The following is a description of a gene set: A biological process that directly contributes to the process of producing new individuals by one or two organisms. The new individuals inherit some proportion of their genetic material from the parent or parents. studied in species Homo sapiens Human Gene Set: GOBP_REPRODUCTIVE_PROCESS, and this is the list of marker genes: LRGUK, STAU1, HSPG2, GHRL, MTA2, TDRD5, ADAMTS16, ITGB3, AVPR1A, FZR1, RFX2, C1QBP (complement C1q binding protein), GDF7, TTC12, ADAM29, CDYL, CTCFL, CCNA1, MAPK15, DIRAS3, FOLR2, KDM3A, SYCE1, SPIN2A, TACR2, TMED2, DEFB126, ZP2, ADAM28, E2F8, CATSPERZ, ATP1A4, TH, BSPH1, PGAM2, SFRP1, PRKG1, MARF1, GLIPR1L2, LHFPL2, PAFAH1B3, IHH, LSM14B, NUF2, MEIKIN, NR6A1, NCAPH, PIWIL4, CDK16, HOXD13, TAC1, CLDN11, MOS, GABRB3, KDM2B, SPIN4, SLC19A1, VIPAS39, CYLC1, AKT1, PGK2, OSBP2, SKA1, PTPRN, DDB1, SLC2A14, INSR, CABYR, FOXA1, TSPY1, CDC20, KRT19, GLRA1, NELL2, CCNB1, ROBO2, OSR1, SPOCD1, SYCP2, STK33, EDN1 (endothelin 1), AKAP3, AAAS, MTOR, PKD1, CITED2, SLC6A4, OOEP, HERPUD2, AURKA, MGAT4D, IRAG2, SUN5, TCTE1 (t-complex-associated-testis-expressed 1), PSG2, AREG, AKR1C3, ERCC4, TESK2, SMC2, WT1, HMGA2, ELL3, PIERCE1, SGO2, AGO4, FAM9C, CDY2B, ENDOU, BCL2L1, KAT8, SPATA31A1, SPIN3, PRKACA, KIFC1 (NCBI Gene Id 95229), SULF1, B4GALT1, SKA2, DNHD1, DLG1, DHCR24, CATSPERG, PPP1R9B (NCBI Gene Id 84687), HMGB2, DND1, HEXB, DAZ1, RAD51C, PHB2 (NCBI Gene Id 11331), NPM2 (nucleophosmin/nucleoplasmin 2), ACVR2A, NCAPD3, JAM3 (NCBI Gene Id 84887), GHRHR, OSGIN2, NDN, BNC1, SPMAP2, FAM9B, IFT20, SUN2, GLRB, PTGDR2, SMC1A, SAFB2, RNF8, HOXB13, RBX1, DNAH1, WNT3, PLN, CALCA, CFAP61, HUS1B, SETX (NCBI Gene Id 85506), DNAH5, CNOT9, TMEM232, TPPP3, TRIP13, ABAT, BMP4, SERPINE2, BCL2L2, CCDC40, UTP14C (UTP14C small subunit processome component), NKAPL, TSSK4, TUBGCP5, PTTG3P, FGFR2, FOXF2, FOLR1, GARIN1A, STK35, SEPTIN12, ZAR1L (zygote arrest 1 like), TLE6, BMPR2, SLC26A3, NBN, NLRP5, FAM170A, TMEM203, DMRTA1, IQCF1 (NCBI Gene Id 132141), PAFAH1B1, EIF5A2, WDR48, EQTN, TSSK6, SOX3, RAD54B, ZNF830, CIMIP2A, FOXJ3, TUT4, ITGA5, RPS6KA2, ODF1, RBMY1B, RHBDD1, SPAG8, TAF7L, NPFF, BRCA2, PAQR5, P2RY1, BAK1, CBX2, PMFBP1, RNF151, FANCL, FAM170B, CNBD2, AKAP4, MAPK8IP2, PTHLH, MSX1, STK3, CFAP68, FCRL3, CAPN2, HNF1B (HNF1 homeobox B), MEI4 (NCBI Gene Id 101928601), PARP1, SLX4, KPNA6, GLIPR1, SEMG2, SSX1, TUBA8, LYZL6, TRIM36, DNAAF3, PSG3, THRA, ARMC12, ITGA2, BCAP31 (NCBI Gene Id 10134), GCM1 (glial cells missing transcription factor 1), DNAI1, CCDC159, CDY1, PGAM4, SMC3, HNF4A, NANOS3, HAND1, TOP6BL, EFHC1, OR2H2, CREM, FER, WIPF3, STRBP, TBC1D21, GPR3, INSRR, CASP8, TTK, TSSK2, VMP1, TXNRD3, KIF18A, NPR2, PIWIL2, TFAP2C, SCX, EIF2B2, EOMES, KIF9, ACOX1, SLC26A8, TLR3, ADAM32, SPAG16, CFAP107, CRTAP, GDF10, CCNI, PSG7, CCDC136, GARIN2, CENPS, C2CD6, PZP, NPPC, ADCYAP1R1, ST14, PFN4, ESPL1, CFAP161, CCIN, GATA1 (GATA binding protein 1), LDHC, H1-9P, ZC3H14, TOPAZ1, LAMB1, COL6A1 (collagen type VI alpha 1 chain), SPINT2, WNT7A (NCBI Gene Id 7476), SPINK13, ADAM30, MLH3, NOS3, EHMT2, FUT10, SPINK1, CDC27, CORIN, SPANXB1, INPP5B, SRD5A1, RPL29, FGF10, PRKAG1, LDOC1, H3-3B, FOXC1, CGA, SNU13, PITHD1, FSHR, PIWIL1, SPATA2, ALPL, METTL3, CACNA1H, PRMT7, FZD4, SCGB1A1, CRIP1, SPATA31A6, PROK2, FEM1B, CFAP206, MASTL, TOP2B, MORC1, YTHDC2, WEE2, GDF9, TYRO3, GNPDA1, CFAP47, INTS1 (integrator complex subunit 1), YIF1B, NR2F2, SPAG17, YTHDF3, CRKL, STAT5B, CHD7, IGF2R, TAF4, TEKT5, TEKT1, CRISP3, PTCH1, OR1D2 (NCBI Gene Id 4991), MEI1, IGFBP7, SPTBN4, ADGRG2, SSTR1, ATRX, CRH, RIMS1, CBY3 (NCBI Gene Id 647934), B4GALNT1, MEIOB, NME8, MYH9, TUT7, UBB, NODAL (nodal growth differentiation factor), CFAP58, BMP7, ACSBG2, UBE2Q1, DDO, TEAD4, ORC4, BMP6, H3-4, PLA2G3, VPS13B, SPMIP7, TSGA10, SPATA31A3, ASB1, CTNNA1, CCR6, EPOR, SLC2A8, SPMIP8, THRB, RHOBTB3, REDIC1 (NCBI Gene Id 283461), TUBGCP2, SPAM1, BPY2, SPACA6 (NCBI Gene Id 730718), RBM7, PSG11, SEBOX, HERC2, INCENP, PRM2, RETN, GSK3A, PATZ1, SNAI1, FUT7, KATNAL1, SEPTIN6, LARP7, DEDD, HOOK1, RNF212B, H2BC1, PDILT, BASP1, SMAD3, SPATA31D3, HROB, CEP57, KRT8, PANX1, PKMYT1, RPA1, PARK7, QKI, SPDYA, NOTCH1, ADGB, CRISP1, NKX3-1, DPCD, SLCO4C1, PRSS21, TEX14, MAGED2, SPHK2, EME2, AFG2A, CCDC39, ADIG, TP63, C9orf78 (chromosome 9 open reading frame 78), ADAM18, EMP2, GJA1, PPARD, ITPR1, CCDC63, TRPC6, SOX15, AVP, CATSPER2, USP9Y, CCT7, TIFAB, ADAM21, NPAS1, IL1A, PKDREJ, SLC4A2, IZUMO3, CELF3, ENSG00000274276, PRKDC (protein kinase, DNA-activated, catalytic subunit), TTLL5, CEP131, SPATA19, DMRT1, DPY19L2, CCDC146, SKIL, RAD21, ANG, PTPN11, RAB3A, MUS81, FBXW11, VGF, TPPP2, TIMP1 (NCBI Gene Id 7076), TDRD6, TEX15, SFRP2, LEP, SPIN2B, SMAD2, CFAP141, DRD1, CT55, PSG6, PRR19, NECTIN2, SPAG6, CTCF, SNRPA1, DHX37, AGO2 (argonaute RISC catalytic component 2), FANCG, CSF1, SPACDR, SELENOF, DRC1, TTLL9, OR7C1, CFAP90, CCNO, ESR1, DUSP21, BTG1, SOHLH1, DSG2, HERC4, DCST1, GATA4, HVCN1, NEURL1, CADM1, ANAPC13, MST1R, SEPTIN7 (NCBI Gene Id 989), WASHC5, DLD, DAZAP1 (DAZ associated protein 1), PTGFR, SYT6, FSHB, SOX9, VEGFA, GORASP2, HDAC2, SPMIP10, IZUMO1, SMAD5, DMC1, SRPK1 (NCBI Gene Id 6732), MYCN, PSG4 (NCBI Gene Id 91051), UBE3A, PLG, ASH1L, BOK, CHN2, AGFG1, NTRK1, SAXO4, NUMA1, DNAJB6, STOX2, SOX30, SOHLH2, POC1A, TSNAXIP1, PNLDC1, AMHR2, CDC16, ODAD3 (outer dynein arm docking complex subunit 3), TARBP2, SMC1B, BCL6, CLXN, PSMC3IP, PDE3A, SLC2A1, ZDBF2 (NCBI Gene Id 57683), MKKS, COL16A1, PLA2G4C, GHSR, GAS2, AGFG2, IQUB, SPEM3, SEPTIN4, WBP2NL, MSTN, ARHGDIB, CATSPER1, MROH2B, SLC9C1, DDX3Y, FBXO43, LLCFC1, DCAF17, HOXA13, CDC23, TNFAIP6, HSD17B3 (hydroxysteroid 17-beta dehydrogenase 3), FAM9A, UNC5C, SYT8, ADRA2A, TNP2, SPAG11B, ACTR3, CETN2, CLOCK, ACE, PTGIS, UBAP2L, NANOS1, P3H4, PLCB1, TRO, KIAA0319L, WNT5A, HEXA, ANGPT2, IQCH, RPL39L, RXRB, EPN1, ENKUR, RXFP1, CCDC42, SPATA31A5 (SPATA31 subfamily A member 5), PTX3, CCER1, RIMBP3B, ROPN1, COX7B2, IL11RA, SIRT7, ZMYND12, TBPL1, STS, CATSPERE (catsper channel auxiliary subunit epsilon), CFAP77, PAPPA, SPATA6, TGFB1, CFTR, UBR2, GFRA1, TEX12, CFAP57, KMT2D, EPC1, DNAAF6 (NCBI Gene Id 139212), LEPR, CYLC2, AMH, DHX36, SEPTIN1, GGNBP1, LHCGR, RBBP8, ING2, SYCE1L, USP26 (ubiquitin specific peptidase 26), CYP19A1, MCM9, BPY2C, ROPN1L, KASH5, BRDT, EAF2, FAM50A, MAK, TRIM27, EFHC2, SELENOP, ABCB1, C16orf92, HPGDS (hematopoietic prostaglandin D synthase), PRDX4, SLC9B1, CCND1, PPP2R1A, TERB2, GALNT3, TTLL3, SMURF2, DRC7, OR10J1, CDC25B, VDAC2, ZFPM2, SOX17, CFAP276, EME1, BBS1, FOXJ1, LRRC46, ELSPBP1, HAS2, CLIC4, TERF1 (NCBI Gene Id 7013), XKRY, REC8, TCP11, CSDE1, PTN, SPIRE2, NOTCH4, GAMT, SALL1, SOX8, PSG5, CFAP97D1, ACTL9, KNL1, LGR4, HCN1, TUBG2, RACGAP1, DCST2 (DC-STAMP domain containing 2), CFAP20, ZGLP1, ZNF541, KDM1B, TSSK1B, DUSP13B, DNALI1, KITLG, FANCM, CATSPER3, CNTFR, CGB7, H1-1, TRIM75, SPACA9, ADAMTS1, SP3, NR0B1, AFF4, PRND, AGRP, IQCN, KHDRBS1, FETUB, CFAP126, PYGO2, TTC21A, BBS4, VCX, NCOR2, AP3B1, ASF1B, GRHL2, TUBA1A, CIB1, TEX19, CENPX, SYNE1, CATSPERD, NEK2 (NCBI Gene Id 4751), HFM1, IMMP2L, ANTXR2, CFAP43, PIWIL3, TGFB2, LHX9, DEAF1, ACE2, CALR, HOXA10, BRME1, PIERCE2, MAFF, CCDC87 (NCBI Gene Id 55231), ZAN, CCT8, ABCC8 (ATP binding cassette subfamily C member 8), UBE2J1, RB1, CCNYL1, GMCL2, SPATA31C2, NASP (nuclear autoantigenic sperm protein), OVCH2, MSH5, RSPH6A, NPPA, NRIP1 (NCBI Gene Id 8204), OVOL1, PLK1, CFAP157, LRRC8A, MDK, UBTFL1, PCDH11Y, NPY5R, HSD11B2, CALR3, STC1, SLC25A31, TDRP, H2AX, ZMIZ1, BBOF1, FAM209A, PRSS42P, FOXO3, IZUMO1R, FKBP4, FCRL5, PCNA, MBD2, BIRC3, PGM3, KRAS, MSX2, BSG, UMODL1, WDR54, PRLHR (NCBI Gene Id 9347), STRA6, PRLR (NCBI Gene Id 5618), IGSF8, MAEL, TEX11, PDCL2 (NCBI Gene Id 132954), PLB1, TERB1, QRICH2, RAB24, SMARCC1, ROS1, GMCL1, MAST2, LIN28A, CTSB, NUPR1, PSG1, NUP210L, SPATA22, A1CF, MAMLD1, SOD1, USP17L2, FOXL2, BOLL, TUBGCP4, CCNB2, PLA2G10, DNMT3L, CDK2 (NCBI Gene Id 1017), PPP2CA, HOATZ, IRX5, SPACA5B, CDY1B, ADCY7, PTGDS, NR3C1, RXFP2, YBX2, ADA, PLAG1, ACTR2, CASP3, JAM2, DACH1, CD9, PYGO1, CRHR1 (NCBI Gene Id 1394), WNT9B, MLH1, ADAM2 (NCBI Gene Id 2515), IL12B (interleukin 12B), ETV5, TEX46, ACVR1B, BCKDK, NEURL4, LFNG, RAD51D, DMRTC2, PHC2, ARMC2, NCAPH2, CCNB3, DHH, HSF2BP (NCBI Gene Id 11077), DDX3X, PSAPL1, FBN2, ADCY3, SMC4, CENPI, UCHL1, FBXO5, ZAR1, HOXA9, CASP2, C3orf62, SIX4, CCNB1IP1, TEKT2, FOS, MEA1, LRP2, USP9X, HMX3, SPACA4 (NCBI Gene Id 171169), ABHD2, MEIOC, CRHBP, PRPS1L1, EFHB, ADCY10, TSPY4, TBC1D20, NME7, ACR, SSH2, GMNC, TESK1, GRN, FGF8, WFDC2, TCP11X2, PSMA8, HADH, FMN2, CYP27B1, DLEC1 (NCBI Gene Id 9940), MEIOSIN, CLGN, ALKBH5, RAD1, NKX2-1, AXDND1, RAB13, TESC, PLTP, YTHDC1, PSAP, EIF2B4, ZNF148 (NCBI Gene Id 7707), TSSK3, SPACA5, ADAD1, ZFP42 (ZFP42 zinc finger protein), FXR1, CNTD1, TSPY10, SPP1, PANK2, DSG1, CBS, OXT, LRRK2, UNC13B, NPHP1, RGS2, UPRT, LIF, DMRTA2, CAPZA3, SLC19A2, EDNRA, CEP78, RRM1, HSPA1L, TIPARP, CCDC62, PPP1CC, DAZL, PACRG, KCTD19, SYCE2, CFAP69, FUOM, GLIPR1L1, EPYC, BMPR1B, DMRTB1, CFAP221, AZIN2, CFAP44, OVGP1, CBL, ATP2B4, SLIT3, CD2AP, APOB, RAD54L, WNT4, SMAD4, TNC, ADCYAP1, HSD17B4, STAU2, TPGS1, MYCBPAP, SIAH1, MYCBP, DRD5 (dopamine receptor D5), ZFP57, ATM, CCDC38, CDKN1C, NDRG3, SLIRP (NCBI Gene Id 81892), IDH1, CIBAR1, ANKLE1, TMPRSS12, CTSH, RECK, DACH2 (NCBI Gene Id 117154), SMARCA2, TESMIN, FZD5, BUB3, NICOL1, SIRT1, GGNBP2, ADRA2B, SPATA32, CELF1, ANAPC11, SPIN1, TAC3, CFAP91 (cilia and flagella associated protein 91), SHISA6, PBX1, C1orf146, MSH2, NANOS2, KLF1, FAM209B, GOLGA2, GARIN1B, CABS1, MIR15B, TAC4, DZIP1, VDR, XRCC2, DAZ4, RIBC1, SPACA1, MYOCD, ZNF628, TEX101, SPACA7, ZWINT, MCIDAS, BAX, H1-7, NDC1, CKS2, MMP14, PRSS55, RBP4, KLHL10, AMBP, ZNF318, RAN (NCBI Gene Id 87046), MYBL1, ACVR1, ANAPC10, CREB3L4, UBXN8, IFTAP, PI3, IRGC, TCP11X1, CEP128, MNS1, PTGS2, ASTL, PRKACG, POC1B, DDX20, UTF1, IGFBP5, CDY2A, ANAPC2, PTTG2, WNT2B, SRC, FBLN1, SPEF2, REN (NCBI Gene Id 5972), NUP107, CFAP251, GAL3ST1, HAVCR2, STAG3, LGALS9, EED, HSPA2, TEKT4, SMAD1, SYCE3, EDNRB, LHB, SPATA20, CGB3, NPHP4, ACSL4, ACTL7A, FOXJ2, CCT2, TBATA, FSIP2, RARA, ATAT1, GALNTL5, TSPY3, CCT3, CFAP210, SERPINF1, ARMC3, PLD6, KRT9, ADAM20 (ADAM metallopeptidase domain 20), PIAS1, SPEM1, TTLL1, INHBA, ZCWPW1, GARIN3, MORN2, PAEP, SPATA31D1, DDX6, RNF2, CATSPER4, DMRT3, TDRD1, EGR1, GREB1L, KIT, M1AP, EIF4H, TXNDC8, PCYT1B, ITGB4, INSL3, NEUROG1, AXL, IRF2BPL, KDM5B, SASS6, DCAF13, TUBB4B, UPF3A, KLK14, SHCBP1L, BAG6, RNF114, CFAP45, SPATA9, AURKC, GGT1, GLIPR2, PRDM14, FANCE, CSMD1, PTEN, PCSK5, ELF5, GAS8, BIK, EIF2S2, TPST2 (NCBI Gene Id 8459), RARG, KLHDC3, IFT25 (NCBI Gene Id 51668), LY6K, RSPH1, SLC38A1, SERPINA10, CATSPERB, ICA1L, SPATC1L, MIR21, TEAD3, C3, TCP1, MRE11, IFT56, EIF4G3, INTS13, YY1, SGPL1, STC2, SFMBT1, MCMDC2, PTGDR, FST, SPATA31D4, DAZ3, RAD51B, FIGNL1 (NCBI Gene Id 63979), IGFBP2, SLC38A3, TAF1L, INHA, SYCP3, SPINK2, CCNE2, TLR5, ZNF35, SPA17, IDO1, FOLR3, FRS2, RMI1, SUFU, PCSK4, SPO11, ITGB1, MMP2, GTSF1, BMAL1, RAI14, MTNR1A (NCBI Gene Id 4543), DIAPH2, PAIP2, STRA8, SPMIP11, BCL2, SLC26A6, CCT4 (NCBI Gene Id 10575), DNAJC19, CYP26B1, CDKL2 (cyclin dependent kinase like 2), TSPY8, MERTK (NCBI Gene Id 10461), NCOA1, TTLL8, ANAPC15, DPY19L2P2, DEFB1, TAF4B, CREBRF, MIR455, ANKRD49, TRIM28, SPAG4, SPATA6L, PTTG1, ADAD2, ASZ1, BRIP1, P2RX1 (NCBI Gene Id 5023), SRY, SPANXA2 (SPANX family member A2), KDR, TCF23, CDC26, GJA10, SPATA24, OCA2, CTDNEP1, TGFB3, EPO, GPX4, STK11, PRDM1, SHB, ACRBP, PPP3R2, ANKRD31, HOXD9, IFT27, TCFL5, TXNDC2, TOP3A, DEFB118, ERCC1, STAG2, ZFP41, ARRDC5, CRISP2, PAX5, PLCZ1, NR5A2, ANAPC1, WDR19, MCM8, BMPR1A, FNDC3A, SCAPER, TDRD12, TEKTL1, MKRN2, LZTFL1, PARN, PDGFRA, YTHDF2, SMCP, PRDM9, MSH4, TUBGCP3, ALOX15B, CCNY, TEKTIP1, NPAP1, CAD, POLR1B, PGR, OXTR, CEBPB (NCBI Gene Id 90277), ADAM15, SLC22A14, CDC25C, SLIT2, SORD, SIX3, GAL, LNPEP, PIK3CA, CA12, PUM1, STK4, CD46, TMEM81, SLC9A8, BCAS2, NSUN2, HYAL3, SHOC1, ZNF296, RAD51 (RAD51 recombinase), PRDX3, CTNNB1, ATP8B3, FUT6, PPP1R1B, RIMBP3, RAD23B (RAD23 homolog B, nucleotide excision repair protein), RNASE10, ETV6, TEKT3, ZP4, ANAPC7 (NCBI Gene Id 51434), HOXA11, TDRD7, FIGLA, CFAP54, DNAH11, CCNE1, PARP2, DAZ2, CCT5, STX2, IGF2, PAQR8, NOBOX, GNAS, MDFI, BBS2 (Bardet-Biedl syndrome 2), RIBC2, EDDM3A, LHX1 (LIM homeobox 1), SENP2, RDH10, CLDN4, MND1, SPATA31A7, APOL2 (apolipoprotein L2), HORMAD1, RNF38, NECTIN3, RPL10L, MEIG1, RAD50, H1-6, BMP5, TDRD9, SUN1, NR2C2, FGF9 (NCBI Gene Id 2254), ODF4, KCNU1, BCL2L10, BCL2L11, STAT5A, SLC9B2, CIMIP2C, CELF4, ACVR1C, BRINP1, PRM3, EFCAB9, ACRV1, DDX4, PDIK1L, BPY2B, SEMG1, MFSD14A, SOS1, NCOA4, NME5, PSG9, LGR5, HSF5, FOXA3, XRN2, OPRK1, CYP7B1, MOV10L1, CDKN1B, TACR3, DMRT2 (doublesex and mab-3 related transcription factor 2), ZP1, EXD1, JAG2 (jagged canonical Notch ligand 2), RBM46, CYP1A1, SPMIP6, REC114, CCDC34, LYZL4, TSPAN8, DDX25, CFAP52, OAZ3, PRL, ZMYND15, ADAMTS2, GLI1, EXO1, OOSP2, IGF1, LRRC23, SERPINB5, ZFY, THBD, TMEM119, DBH, CCDC182, RLN1, ACOD1, NR5A1, INHBB, GARIN4, ARID4A, TUBB8, RPS6KB1 (NCBI Gene Id 6796), BMP15, VPS54, NIPBL, UBE2B, PMCH, HSF2, YBX3, MSH6, APP, CENPC, SPATA16, SPATA31E1, GAPDHS (NCBI Gene Id 26330), FBXO24, ANAPC16, PNOC, NOX5, TLR9, APLF, CHFR, CXADR, RLN2, ZPBP, SHH, SPATA46, DNMT3A, PAFAH1B2, SBF1, H3-3A, CDK1, PSMD13 (NCBI Gene Id 5719), DDR1, SLC38A2, LCN6 (lipocalin 6), GK2, HORMAD2, FANCD2, IL1B, TMEM95, ITGA3, TACR1, STAT3, ZBTB16, SPAG1, GGN, PLEKHA1, PARP11, UCN, PLCD4, AFP, SYDE1, SKA3, TRPC3, SPANXA1, SPPL2C, APELA (NCBI Gene Id 100506013), ZNF449, RIMBP3C, FREY1, ZSCAN2, SPMIP9, TSPY9, CUL4A, NOG, ZPBP2, TNP1, WDR77, FKBP6, RNF17, HOXD10, DYNLL1, SGO1, TBX3, CHD5, ASPM, FEV, EIF2B5, CFAP95, TSPY2, ARID4B, MAP3K4, VDAC3, ATN1, CD38, PRM1, RUVBL1, SPESP1, AR, TSNAX, CIMAP1A, MMP9, MFGE8, SIX5, E2F1 (E2F transcription factor 1), TUBG1, RNF212, HPGD, NDP, NCAPD2, CFAP53, SERPINA5, IHO1 (NCBI Gene Id 339834), RAC1, BTBD18, FLNA, RAD51AP1, PRSS37, HUS1, STXBP1, DUSP1, ARID5B, DNAAF11, HESX1, GABRB1, SLC22A16, DKKL1, PLA2G4B, TUBGCP6, KLC3, CFAP119, ADGRG1, H1-8, SPACA3, ANAPC4, TMF1, MMP19, TOP2A, NHLH2, RAD21L1, WDR33, GPR149, ACVR2B, GATA3, ZP3, ERRFI1, BRD2, SYCP1, NDC80, DCANP1, IQCG, SEPTIN2, NLRP14, JUNB, GNRH1, ROPN1B, ZSCAN21, CYP17A1, C14orf39, SEPTIN14, CFAP144, ZW10, PLAT, SPATA31C1, FANCA, PSME4, ANAPC5, TOB2, CFAP65, CDC25A, ADAM7, FOSB, GATA6, ODF2, ID4, VPS13A, LIMK2, EREG, MIR16-1, CSNK2A2, KAT5, FOSL1, ALDOA, METTL14, SIRT2, IFT81, ADNP, TDRKH, EPPIN, MAJIN, USP42, MECP2, SPATA25, TCF21, E2F7, EFCAB6, GJB5, CECR2, SRD5A2, MED1, PAQR7, CNTLN, HSF1, CLIC5, TRPC7, SPIRE1 (NCBI Gene Id 56907), PLK4, TBP (NCBI Gene Id 6908), TGFBR1